The following is a description of a gene set: Human Gene Set: chr2q13 studied in species Homo sapiens, and this is the list of marker genes: MALL, LIMS3, SEPTIN10, SOWAHC, BUB1, RPL22P11, MIR4771-2, RPL39P16, SLC30A6P1, ENSG00000294954, RGPD5, ZBTB45P1, EEF1E1P1, SH3RF3, RANBP2, MIR4265, MIR4266, MIR4435-2HG, LINC01123, CCDC138 (coiled-coil domain containing 138), ENSG00000290731, RPL22P12, PAFAH1B1P2, ENSG00000289202, ZBTB45P2, RTRAFP1, SRSF3P6, FBLN7, SNRPGP9, GPAA1P1, ACTR1AP1, LIMS4, EDAR, DBF4P2, ACOXL-AS1, ANAPC1, LINC01106, RGPD6, MIR4435-2, RPS14P4, MALLP1, ENSG00000293619 (NCBI Gene Id 128966597), RN7SL297P, RPL34P8, TMEM87B, RPL10P5, BMS1P19, RPL5P9 (NCBI Gene Id 100419116), MIR4267, ENSG00000225744, ACOXL, RPL37P12, MTLN, MERTK, CENPNP2, SOCAR, MIR4436B2, MIR4436B1, NPHP1, BCL2L11, GPAA1P2, SH3RF3-AS1